The following is a description of a gene set: Human Gene Set: GOBP_TOLL_LIKE_RECEPTOR_SIGNALING_PATHWAY The series of molecular signals initiated by a ligand binding to a toll-like receptor of a target cell. Toll-like receptors directly bind pattern motifs from a variety of microbial sources to initiate an innate immune response. studied in species Homo sapiens, and this is the list of marker genes: GDI1, TLR4, IRAK1, TLR5, IRAK2, NFKBIL1, MIR19A, S100A9, YWHAE, MIR17, LRRC19, CD274, IRF7, NFKBIZ, TNIP1, LGR4, TLR8, IKBKB, CD300A, HSP90B1, SCIMP, TIFAB, HSPD1, IRF3, IRAK4 (interleukin 1 receptor associated kinase 4), TIRAP, MYD88 (MYD88 innate immune signal transduction adaptor), ARRB2, CCDC134, TLR9, IRAK3, TICAM2, MAPKAPK2, AP3B1, PRKCE, PLCG2, BIRC3, CTSS (cathepsin S), BTK, IRF4, TYRO3, FOSL1, APP, TICAM1, TRAF6, TRAF3, TLR7, MIR146A, TLR2 (toll like receptor 2), NLRP6, TLR3, RPS6KA3, RNF115, ESR1, UNC93B1, MFHAS1 (NCBI Gene Id 9258), RELA, TASL, S100A8, GFI1, BIRC2, MAP3K7, CACTIN, TNIP3, LRCH4, MAPKAPK3, BCL10, CD36, CD300LF, LY96, SARM1, TLR10, IRF1, RAB11FIP2, NLRP2B, TLR1, SMPDL3B, GPR108, REG3G, LRRC14, OTUD4, PDPK1, TLR6, GPS2